The following is a description of a gene set: Genes predicted to be targets of miRBase v22 microRNA mmu_miR_1306_5p in miRDB v6.0 with MirTarget v4 prediction scores > 80 (high confidence targets). species: Mus musculus from publication Chen Y, Wang X (PMID 31504780) Mouse Gene Set: MIR_1306_5P, and this is the list of marker genes: Zfp292, Tfcp2l1, Ankrd34b, Lysmd3, Gm6710, Xbp1, Gpm6a, Akap6, Larp1, Bend3 (NCBI Gene Id 331623), Cspp1, Actr2, Dlg4, Garnl3, Olfm1, Ccng1, Fubp3, Eif4a2, Zbtb4, Cebpd